Given this list of marker genes Ginm1, B230219D22Rik, Cdh12, Fam174a, 1700066M21Rik, Slc17a8, Mtch2, Ptprr, Dlc1, Rps15a, Vps29, Hccs, Slc6a15, Scd3, Bbs10, Pdzd2, Dipk2b (NCBI Gene Id 75905), Man2a1, Nr3c1, Ica1l, Naa30, Tsc22d2, Pnma8b, Slc8a1 (solute carrier family 8 (sodium/calcium exchanger), member 1), Gpr82, Pitpnm2, Taf12, Rcn1, Plcxd2, Rnpc3, Dusp3, Mef2c, Lpcat2b, Trak1, Ankrd13b, Wsb1, Arsa, Phaf1, Ash1l, Dolk, Slc38a2, Dyrk1a, Cxcr2, Nedd9, Hyal6, Grm7, Il17rd, Gclm, Mbnl2 (muscleblind like splicing factor 2), Cdh11, Klhl24, Cab39l, Tnpo1, Rnf152, Rspo3, Hnrnpa2b1, Alkal1, Tbx2, Zbtb5, Rgs1, U2surp (NCBI Gene Id 67958), Dach1, Tmx2, Gab2, Bbx, Cyld, Bmi1, Galnt13, Robo2, Fat3 (NCBI Gene Id 382129), Stra6l, Tnrc6b, Grk3, Fam120b, Nav1, Mab21l2, Mkrn1, Sec23ip, Nhsl2, Dnm3, Tacr2, Smarca4, Adar (NCBI Gene Id 99861), Ipcef1, Prkaa2, Mysm1, Samd3, Cyct, Rbm27, Tada2b, Sigmar1, Cbx6, Pdgfd (NCBI Gene Id 71785), Rgl1, Itm2b, Cdnf, Pwwp2a, Zfp827, Stx17, Atrn, Nedd4l, Micu3, Mctp2, Mtmr1, Akap10, Tor1a, Rala, Usp31, Cux1, Ammecr1, Ndst3, Lipa, Fxr1, Gria4, Mtr, Ing5, Zbtb24, Susd6, St8sia3 (NCBI Gene Id 20451), Ngef, Thumpd3, Tardbp, Lurap1l, Son, Slc15a2, here is a description of the gene set: Genes predicted to be targets of miRBase v22 microRNA mmu_miR_103_2_5p in miRDB v6.0 with MirTarget v4 prediction scores > 80 (high confidence targets). Mouse Gene Set: MIR_103_2_5P species: Mus musculus from publication Chen Y, Wang X (PMID 31504780)